Given this list of marker genes DLX4, TYMS, CKAP4, DNER, DAD1, here is a description of the gene set: Although widespread metastasis is the major cause of human lung cancer-related deaths, its underlying mechanism remains largely unclear. Our genome-wide comparison of the expression profiles of a highly metastatic lung cancer cell line, NCI-H460-LNM35 (LNM35), and its parental clone, NCI-H460-N15 (N15), resulted in the identification of a cancer metastasis signature composed of genes. Through gene ontology analysis, our study also provided insights into how this 45-gene metastasis signature may contribute to the acquisition of metastatic potential. By applying the signature to datasets of human cancer cases, we could demonstrate significant associations with a subset of cases with poor prognosis not only for the two datasets of cancers of the lung but also for cancers of the breast. Furthermore, we were able to show that enforced expression of the DLX4 homeobox gene, which was identified as a gene with significant downregulation in LNM35 as well as with significant association with favorable prognosis for lung cancer patients, markedly inhibited in vitro motility and invasion as well as in vivo metastasis via both hematogenous and lymphogenous routes. Taken together, these findings indicate that our combined transcriptome analysis is an efficient approach in the search for genes possessing both clinical usefulness in terms of prognostic prediction in human cancer cases and clear functional relevance for studying cancer biology in relation to metastasis. Human Gene Set: TOMIDA_LUNG_CANCER_POOR_SURVIVAL studied in species Homo sapiens from publication Tomida S, Yanagisawa K, Koshikawa K, Yatabe Y, Mitsudomi T, Osada H, Takahashi T (PMID 17260014) Metastatic signature genes that best distinguished between favorable and unfavorable prognosis for the non-small cell lung cancer (NSCLC) patients.